The following is a description of a gene set: A process that is part of the meiotic cell cycle. Human Gene Set: GOBP_MEIOTIC_CELL_CYCLE_PROCESS studied in species Homo sapiens, and this is the list of marker genes: MSH4, NSUN2, TDRD12, RAD51AP1, SYCP2 (NCBI Gene Id 10388), UBE2B, WEE2, SYCE1L, USP17L2, MLH1, SMC2, PTEN, BRDT, CNTD1, PKMYT1, MLH3, FANCM, SIRT2, RAD51, MEI1, MUS81, EME2, NCAPH2, RAD54L, INCENP, CKS2, FANCD2, ERCC4, MCMDC2, SUN1, TDRD9, DDB1, TEX19, PTTG3P, CDC25B, ZNF541, TEX12, AGO4, TERB1, SPIRE1, CCNB1IP1, MEIOSIN, TDRKH, RPS6KA2, ZSCAN21, NCAPD2, CDC25A, TOP2A, NCAPD3, SKA1, MAEL, SHOC1, DMRT1, PSMD13, SKA2, EREG, GOLGA2, SKA3, TRIM75, DMRTC2, SLX4, RAD51D, RAD21, ESPL1, MRE11, TEX11, REC8, MSX2, PTTG1, HSF2BP, MSH5, TERB2 (telomere repeat binding bouquet formation protein 2), SIRT7, FOXJ2, CCNE2, ACTR2, ATRX, MOS, HSF5, SYCE1, TUBB8, M1AP, NDC80 (NCBI Gene Id 10403), RAD50, AURKA, FOXJ3, SYCE2, LSM14B, KLHDC3, CALR (NCBI Gene Id 811), EHMT2, SLC25A31 (solute carrier family 25 member 31), MSH6, NDC1, HSPA2, C9orf78, DMC1, TTK, PRDM9, STRA8, SPDYA, TUBG2, RAD1, MEIOC, MASTL, WASHC5 (WASH complex subunit 5), MEIOB, TOP2B, CCNB2, DDX4, FANCA, BTBD18, SYCP1, EDNRA, CENPS, TAF1L, BCL2L11, FMN2, KCTD19, IHO1, RNF212, RPL10L, MEI4, HSF1, CCNE1, HUS1B, PSMA8, SPO11, PDE3A, DNMT3L, DCAF13, CDC20, TESMIN, RAD54B, TEX15, CATSPERZ, ATM, NPR2, SPIRE2, SGO1, PSMC3IP, EME1, NCAPH (NCBI Gene Id 679), ZWINT, SPATA22, TRIP13, MND1, EDN1, MSX1, FBXO43, RAB24, TUBG1, RBM46, BAG6, C1orf146, REC114, NANOS2, PDIK1L, FZR1, TERF1, P3H4, HORMAD1 (HORMA domain containing 1), CENPC, STAG3, DAZL, MAJIN, TOP6BL, ASPM, ASZ1, PPP2R1A, SEPTIN1, CHFR, SYCP3, BRIP1, NPM2, ORC4, ANKRD31, FIGNL1, OVOL1, OOEP, CENPX, ING2, NPPC, TEX14, BRME1, PTTG2, WNT5A, PLK1, C14orf39, GPR3, CDC25C, SLC2A8, RMI1, PIWIL2, SHCBP1L, ACTR3, LIF, SYCE3, PLCB1, RAD51B, HUS1, KASH5, FBXO5, KIF18A, RAD51C, WNT4, BRCA2, MOV10L1, CYP26B1, YTHDF2, NUF2, MEIKIN, STK35, SMC4, UBR2, MYBL1, MARF1, ANKLE1, MAPK15, KNL1, MYH9, CCNA1, HFM1, ZCWPW1, RNF212B, UBB